The following is a description of a gene set: part of: Inwardly rectifying K+ channels studied in species Homo sapiens Reactome Pathway: ATP sensitive Potassium channels ATP sensitive K+ channels couple intracellular metabolism with membrane excitability. These channels are inhibited by ATP so are open in low metabolic states and close in high metabolic states, resulting in membrane depolarization triggering responses such as insulin secretion, modulation of vascular smooth muscle and cardioprotection. The channel comprises four Kir6.x subunits and four regulatory sulphonylurea receptors (SUR)., and this is the list of marker genes: KCNJ8, KCNJ11, ABCC9 (ATP binding cassette subfamily C member 9), ABCC8